The following is a description of a gene set: from publication Sarkar S, Kalia V, Haining WN, Konieczny BT, Subramaniam S, Ahmed R (PMID 18316415) Human Gene Set: GSE10239_NAIVE_VS_MEMORY_CD8_TCELL_DN Genes down-regulated in comparison of naive CD8 T cells versus memory CD8 T cells. studied in species Homo sapiens Using killer cell lectin-like receptor G1 as a marker to distinguish terminal effector cells from memory precursors, we found that despite their diverse cell fates both subsets possessed remarkably similar gene expression profiles and functioned as equally potent killer cells. However, only the memory precursors were capable of making IL-2 thus defining a novel effector cell that was cytotoxic, expressed granzyme B, and produced inflammatory cytokines in addition to IL-2. This effector population then differentiated into long-lived protective memory T cells capable of self-renewal and rapid re-call responses. Mechanistic studies showed that cells that continued to receive antigenic stimulation during the later stages of infection were more likely to become terminal effectors. Importantly, curtailing antigenic stimulation towards the tail-end of the acute infection enhanced the generation of memory cells. These studies support the decreasing potential model of memory differentiation and show that the duration of antigenic stimulation is a critical regulator of memory formation, and this is the list of marker genes: PPP4R3A, KLHL11, HLA-A, PLA2G12A, NEDD8, GFOD1 (NCBI Gene Id 96191), PER3, SCLY, NRP1, YES1, UQCR10, CD84, FREY1, MRPL20, GORASP1, DOK4, KIFC3, ID2, CD248, CLEC16A, IKZF3, ACOT7, JAM2, SHISA3, EIF2AK2, MAX, ADAM33, AP2A1, RGS3, SLAMF7, DBNDD2, OXT, ZNF646, SNRPD1, CHRM4, S100A5, HNRNPAB, S100A10, PRDM14, COMMD6, NPPA, SDCBP2, CCR3, PLCB2, RPS10, RHBDF2, ZDHHC22 (zinc finger DHHC-type palmitoyltransferase 22), RPL38, PFDN5, EHBP1L1, RPL17, P2RY12, SUB1, TMEM239, SEC61G, CRTAM, URM1, SOX15, SCHIP1, LYPD5, SERPINA12, FKBP2, INHBB, ARPP19, BBOF1 (basal body orientation factor 1), RAMAC, NPR1, ICOSLG, CCR5, RPL11, CRB1, NRXN2, MYCBPAP, SP110, TCF7L1, NTRK2, IFNG, COX20, CD244, LAMTOR2, ANXA9, COX6C, S100A13, SMPDL3B, KLRK1 (killer cell lectin like receptor K1), ZNF865, PLAAT3, CENPN, UBE2N, CMC1, ANKRD49, ATP5MG, RAP1GAP, SLC34A1, TPRN, IL18R1, NFKB2, NDUFS5, SLC35G6, ARL4D, FAH, GIP, ZNF444, PTPN13, MLPH, SLC18A3, FCGR2B (NCBI Gene Id 2213), DACH1, APIP, AKT1S1, CCDC106, VAX2, HACD4, PHACTR3, ATP5MC2, OMP, COL5A1, RIBC2, CD3G, OPN4 (opsin 4), OLR1, NCALD, DYNLRB1, GJD2, TAFA3, SNX10, MDFIC, SEPTIN2, BEST1, GTSE1, RPL37, DSC3, THY1 (Thy-1 cell surface antigen), FOXO4, MB21D2, R3HDM2, PTBP1, ATXN1, AHDC1, ZBTB8OS, SUSD5, MPST, ENTPD1 (NCBI Gene Id 953), GRID2, ZBTB39, DNAJC15, MROH2A, PPFIA4, POGK, GRAP, ABCB10, CRIP1 (NCBI Gene Id 1396), UBL7, FAM170A, TSPAN12, RPL32, DTD2, COL27A1, TRPM6, ZFPM1, RGS1, RPTN (NCBI Gene Id 126638), CNTFR, TFR2, SPAG7, IL1RAPL2, POMP, FRYL, LPP-AS2 (NCBI Gene Id 339929), MAPRE2, CIMIP1, TAF12, NDUFA7 (NADH:ubiquinone oxidoreductase subunit A7), BTF3, ACSBG1, TTLL7, WNT16, GOT1L1, S100A11, C4orf36, CASP1, TEX35, GMFG, RHOC, KGD4 (alpha-ketoglutarate dehydrogenase subunit 4), EPS8L3, CD68, GSTT1, PLCD1, SPI1, TMEM89, TIPIN, CYTH4, KLF1, SNORD123, HCG4, UST, SELP